Given this list of marker genes HNF1B, OSR1, NOG, SIX4, SIX1, GDNF, GREM1, HS2ST1, WNT9B, GATA3, here is a description of the gene set: species: Homo sapiens The developmental process pertaining to the initial formation of a mesonephric tubule from unspecified parts. A mesonephric tubule is an epithelial tube that is part of the mesonephros. Human Gene Set: GOBP_MESONEPHRIC_TUBULE_FORMATION